Given this list of marker genes IL10, GBA1, KLRC4, STAT4, CCR1, ADA2, PRKAR1A, FAS, IL23R, TLR4, IFNGR1, C4A, IL12A, MEFV, HLA-B, ERAP1, IL12A-AS1, UBAC2, here is a description of the gene set: studied in species Homo sapiens An inflammation of the endocardium, the inner layer of the heart, which usually involves the heart valves. Endocarditis Human Gene Set: HP_ENDOCARDITIS